Given this list of marker genes NKX3-1, TBX3 (NCBI Gene Id 91834), CD44, THBD, RASSF5, CXCL12, CDKN2C, PAX5, CYP27B1, NKX2-8, CDH13, TNFSF9, KLHL35, PAX7, PRKG1, POU3F1, PMP22, GADD45G, MT3, GJB2, PCDH11X, TCEAL1, RIPK3, TBX1, EVA1C, ETFA, PGR, RBP4, RARA, CEBPD, VDR, BCL2 (NCBI Gene Id 596), KCNQ1, SLIT1, SFRP5, DUSP6, PPP1R13B, PAX6, CCNA1, KLF4, SFRP1, EPHX3, NR2F2, WT1-AS (NCBI Gene Id 53590), LAMA3, APBA1, TP73, FEZ1, CRIP1, RBP7, FOXA2, NDRG1, PXMP2, HOXB13, JUN, FBN1, HIC1 (NCBI Gene Id 3090), DCC, TFAP2C, TNFRSF25, ALX3, CDX2, CACNA1G, WT1, DLC1, GATA5, NTRK2, CHRDL1, CALCA, GATA4, KISS1R, MYOD1, FOXE1, CDH4, PYCARD, GPC3, ZACN, GNAS, MT1A, ASIC2, DSC3, NPTX1, LGALS3, HBA1, AMN, EGR3, PTHLH, HRK, here is a description of the gene set: Genes bearing H3K27me3 mark or whose promoters are bound by the polycomb proteins SUZ12 or EED; their DNA is methylated de novo in cancer. studied in species Homo sapiens Many genes associated with CpG islands undergo de novo methylation in cancer. Studies have suggested that the pattern of this modification may be partially determined by an instructive mechanism that recognizes specifically marked regions of the genome. Using chromatin immunoprecipitation analysis, here we show that genes methylated in cancer cells are specifically packaged with nucleosomes containing histone H3 trimethylated on Lys27. This chromatin mark is established on these unmethylated CpG island genes early in development and then maintained in differentiated cell types by the presence of an EZH2-containing Polycomb complex. In cancer cells, as opposed to normal cells, the presence of this complex brings about the recruitment of DNA methyl transferases, leading to de novo methylation. These results suggest that tumor-specific targeting of de novo methylation is pre-programmed by an established epigenetic system that normally has a role in marking embryonic genes for repression. from publication Schlesinger Y, Straussman R, Keshet I, Farkash S, Hecht M, Zimmerman J, Eden E, Yakhini Z, Ben-Shushan E, Reubinoff BE, Bergman Y, Simon I, Cedar H (PMID 17200670) Human Gene Set: SCHLESINGER_METHYLATED_DE_NOVO_IN_CANCER